The following is a description of a gene set: Mouse Gene Set: MIR_6962_3P from publication Chen Y, Wang X (PMID 31504780) Genes predicted to be targets of miRBase v22 microRNA mmu_miR_6962_3p in miRDB v6.0 with MirTarget v4 prediction scores > 80 (high confidence targets). studied in species Mus musculus, and this is the list of marker genes: Cox7b, Efna5, Aplp2, Mbd5, Dab1, Phf20l1, Reps2, Wdr3, Hdgfl3 (NCBI Gene Id 72589), Grm5, Scara5, Ncam2, Tdrd3, Otx2, Zfp971, Egfr, Zfp608, Fgd4, Vipr1, Fign, Lrtm1, Atp1b4, Arhgef9 (CDC42 guanine nucleotide exchange factor 9), Ddx3x, Pabir3, Zfp68, Cited2, Shoc2, Phip, Wwtr1, Ids, Hadhb, Rpl17, Ptges3, Gm14295, Camk2g, St8sia2, Anxa1, Pdap1, Inpp4b, Cdh15, Sbk1, Nfkbiz